Given this list of marker genes RXRA, NR1H3, RXRB, MYLIP, NR1H2, here is a description of the gene set: NR1H2 & NR1H3 regulate gene expression to limit cholesterol uptake species: Homo sapiens Human Gene Set: REACTOME_NR1H2_NR1H3_REGULATE_GENE_EXPRESSION_TO_LIMIT_CHOLESTEROL_UPTAKE